Given this list of marker genes Zdhhc7, Cdc14a, Sorcs2, Klhl20, Dcun1d5, Nr3c1, Agbl3, Smg1, Zfp322a, Phip, Hmgcll1, Rbm24, Meioc, Dnajb3, Unc5d, Susd5, Cdh12, Cops3 (NCBI Gene Id 26890), Katnbl1, Rfx3, Snx27, Sav1, Pak2, Fam90a1a, Dcstamp, Slco2b1, Ing2, Zbtb44, Rasal2, Lyplal1, Bcl2l11, Impact, Sulf2, Mios, L3mbtl3, Wnk3, Lats1, Cadm2, Gucy1a2, Ogt, Arv1, Cbfb, Prpsap1, Crebrf, Rpp14, Arcn1, Pard3b, Zfp748, Igdcc4, Tbx18 (NCBI Gene Id 76365), Fbxl22, Crisp2, Glyr1, Tnip1, Bmpr1a, Kcnn2, Scn11a, Pnisr, Cmklr2, Cyp2j5 (cytochrome P450, family 2, subfamily j, polypeptide 5), Sema3a, Micu3 (mitochondrial calcium uptake family, member 3), Slc30a4, Pakap, Ocln, Asah1, Arih1, Hook3, Acbd3 (NCBI Gene Id 71493), Loxl4, Slc18a2, Cks1brt, Pam, Tle1, Faim2, Adam12, Scai, Cep97, Mecp2, Rbfox2 (NCBI Gene Id 93686), Ino80d, Mybl1, Grm1 (NCBI Gene Id 74875), Pappa, Prrt4, Stk26, Gtf2a1, Larp4b, Itga6, Vma21, Ubn2 (ubinuclein 2), Sema5a, Gm11780, Bmp5, Med13, Mtarc1, Adam22 (a disintegrin and metallopeptidase domain 22), Tmem229a, Prex2, Exoc5, Rsad2, Fgfr2, Ttpa, Ttc39b, Spred1, Nipal1, Vsir (NCBI Gene Id 74048), Tor1aip1, Nfat5, Plekhg1, Mapk9, Gm5431, BC005537, Ercc6, Amot, Kras, Gab3, Atg13, Rhoq, R3hdm4, Sorbs2, Zfp9, Ube2k, Cldn12, Gnpda2, Klrb1f, Bace2, Tram1, Ppp4r2, Habp2, Trps1, Basp1, Rnf149, Ceacam20, Poc1b, Ptbp3, Gnal, Ccn4, Cyp7a1, Glra2, Pcdh7, Cap1, Ms4a4c, Psd3, Sgip1, Dennd1b, Cstf2, Top1, Arhgap42, Ect2, Tmem263, Defb30, Insig2, Rpl5, Ddx46, Taf4, Ube4a, Hsf2, Irag1, Rab2a, Ipo5, Syt14, Serbp1, Usf3, 4930568D16Rik, Taok1, Kazald1, Cemip, Golga7, Smchd1, Vamp2, Spag16, Mtmr7, Pcdh10, Six4, Dop1a, Zfp36l1, Tubgcp4, Dusp18, Slc24a3, Rubcnl, Adamts7, here is a description of the gene set: studied in species Mus musculus Genes predicted to be targets of miRBase v22 microRNA mmu_miR_6984_5p in miRDB v6.0 with MirTarget v4 prediction scores > 80 (high confidence targets). Mouse Gene Set: MIR_6984_5P from publication Chen Y, Wang X (PMID 31504780)